Given this list of marker genes PCCA, ACACA, MCCC1, MCCC2, BTD, ACACB, PCCB, PC, HLCS, here is a description of the gene set: Biotin metabolism, including IMDs Human Gene Set: WP_BIOTIN_METABOLISM_INCLUDING_IMDS studied in species Homo sapiens